The following is a description of a gene set: Human Gene Set: HP_DYSDIADOCHOKINESIS Dysdiadochokinesis studied in species Homo sapiens A type of ataxia characterized by the impairment of the ability to perform rapidly alternating movements, such as pronating and supinating his or her hand on the dorsum of the other hand as rapidly as possible., and this is the list of marker genes: SLC9A1, XRCC4, PLA2G6, SLC20A2 (NCBI Gene Id 6575), VLDLR, GRM1, FMR1, AASS, POU3F4, GJB1, PRDM13, ATN1, SLC30A10, AFG3L2, RFC1, CARS1, FXN, SAMD9L, WDR81, SPTBN2, SLC25A15, GRID2, MRE11, SQSTM1, CAPRIN1 (NCBI Gene Id 4076, cell cycle associated protein 1), SPG21, ATM, XRCC1, FA2H, PNPLA6, ATXN1, ATXN7, NFASC, PDGFB, POLG, ITPR1, CAV1, SLC5A6, ELOVL4, PDE8B, PPP2R2B, TSPOAP1, TUBB4A (tubulin beta 4A class IVa), DAB1 (DAB adaptor protein 1), POLR3B (NCBI Gene Id 55703), TTC19, SPG7, GCH1, ABCB7 (NCBI Gene Id 8252), MSTO1, LMNB1, CLN5, SLC18A2, CCDC88C, KCNJ10, ATXN10, ATXN2, PDGFRB, GGT1, TTPA